Given this list of marker genes Msl2, Msl3l2, Msl3, Kat8, Msl1, here is a description of the gene set: Mouse Gene Set: GOCC_MSL_COMPLEX A histone acetyltransferase complex that catalyzes the acetylation of a histone H4 lysine residue at position 16. In human, it contains the catalytic subunit MOF, and MSL1, MSL2 and MSL3. studied in species Mus musculus